Given this list of marker genes TRPC7, HOXA-AS3, RPL6P19, TEP1, TIGD6, MDFI, CA5BP1, ETS2-AS1, EEF1AKMT3, CDCA4, MTCYBP35, CHL1-AS1, MARVELD3, COL6A2, MIR4514, HNF1A, PRKAR1A, SPSB1, here is a description of the gene set: studied in species Homo sapiens Human Gene Set: NFE2L3_TARGET_GENES from publication Yevshin I, Sharipov R, Kolmykov S, Kondrakhin Y, Kolpakov F (PMID 30445619) Genes containing one or more binding sites for (NFE2L3) in their promoter regions (TSS -1000,+100 bp) as identified by GTRD version 20.06 ChIP-seq harmonization.